Given this list of marker genes UBC, PSMD3, RBX1, CUL1, PSMB7, PSMC3, PSMA1, PSMA4, PSMD13, PSMD1, PSMA7, BTRC (NCBI Gene Id 8945), PSMB3, PSMC5, SEM1, PSMC1, PSMB5, PSMA6, RPS27A, PSMA3, FBXL21P, PSMB1, PER1, CRY2, PSMB4, PSMA2, FBXW11, PSMA5, PSMD11, PSMD14, PSMB2, CRY1, FBXL3, PSMD2, UBE2D1, PER3, PSMC4, PSMD6, PSMD7, PSMD12, PSMC2, SKP1, PSMC6, PSMD8, PSMB6, PER2, UBB, ADRM1, UBA52, here is a description of the gene set: Reactome Pathway: Degradation of CRY and PER proteins In order to initiate a new round of transcription activated by BMAL1:CLOCK in the morning, Cryptochrome proteins (CRY1, CRY2) and Period proteins (PER1, PER2, PER3), the repressors of BMAL:CLOCK, are ubiquitinylated by SCF E3 ligase complexes and then proteolyzed by the 26S proteasome during the night. The BTRC,FBXW11:CUL1:SKP1:RBX1 E3 ligase complex ubiquitinylates phosphorylated PER1, PER2, and likely PER3 in the cytosol, the FBXL3:CUL1:SKP1:RBX1 E3 ligase complex ubiquitinylates CRY1 and CRY2 in the nucleoplasm (inferred from mouse homologs in Busino et al. 2007, Hirano et al. 2013, Yoo et al. 2013), and the FBXL21:CUL1:SKP1:RBX1 E3 ligase complex ubiquitinylates CRY1 and CRY2 in the cytosol (inferred from mouse homologs in Hirano et al. 2013, Yoo et al. 2013). FBLX21 represses ubiquitinylation by FBXL3 in the nucleus by an uncharacterized mechanism (inferred from mouse homologs in Hirano et al. 2013, Yoo et al. 2013) part of: Circadian clock species: Homo sapiens